The following is a description of a gene set: Human Gene Set: GOCC_STEREOCILIUM_TIP A distinct compartment at the tip of a stereocilium, distal to the site of attachment to the apical cell surface. It consists of a dense matrix bridging the barbed ends of the stereocilium actin filaments with the overlying plasma membrane, is dynamic compared to the shaft, and is required for stereocilium elongation. studied in species Homo sapiens, and this is the list of marker genes: PDZD7, PKHD1L1, CDH23, MORN4, HOMER2, CEACAM16, CDC14A, STRC, MYO3A, EPS8L2, ESPNL, TMC2, TMC1 (NCBI Gene Id 53634), LHFPL5, ESPN, WHRN, USH1C, STRCP1, MYO3B (myosin IIIB), EPS8, NHERF1